Given this list of marker genes RAD51B, TGIF2-RAB5IF, JADE1, CDKN2AIP, IRS1, PRR18, PSME3, HLA-DOB, MYLK, HERPUD2, SUFU, ZNF106, LOXL2, SNCA, ATF7, PLP2, SOX6, DDX31, ZNF609, MMAA, SPTY2D1, FBXL7, KDM3B, RRAS2 (NCBI Gene Id 22800), KLF4, TAB2, PTAR1, CCDC43, COMMD7, DPYSL3, OGT, IPO11, CCDC66, DIRAS1, IGSF9B, SP1, ANKRD36B, FPGT, KLF12, QTRT2, KBTBD2, ZNF275, CALM3, RAF1, FNDC4, HS3ST5, TMED9, SLC5A3 (solute carrier family 5 member 3), RSBN1, MAPKAP1, DCSTAMP, RB1, PRKCB, PCDHB15, ISY1, FHIT, RBFOX1, UGGT1 (UDP-glucose glycoprotein glucosyltransferase 1), GATA5, REG3G, GKAP1, TFF3, SEMA4C, KLHL14, CNPPD1, MTFR1L, RSPRY1, ATP2B2, VPS26A, KIF16B, ZNF395, SLC4A7, HPCAL4, UBXN2B, BLOC1S4, HMG20A, DNAH14, SEPTIN8, PDE4A, IDE, GABRA6, CHD3, ZBTB1, ARL8B, TBC1D12, RAB5IF, MECP2, ZBTB22, PIGH, SHANK1 (SH3 and multiple ankyrin repeat domains 1), WDR47, SOCS2, SQSTM1, XPO7, MFSD14B, SLC25A16, KIF13A, PDK3, ICA1L (NCBI Gene Id 65068), ARID4A, SEPTIN10, GRP, FCHO2, SMARCD1, IDS, STIMATE, PLXNA1, DACH1, NDST3, ARF4, FAM168B, EOLA1 (endothelium and lymphocyte associated ASCH domain 1), RBSN, SRRM3, NR4A3, IRS2, NR2C1, GLI3, CHAMP1, ULK2, RPS6KB1, GFM1, RNF144A, MAFG, NREP, MEGF9, P3R3URF-PIK3R3, ATXN1, UBQLN4, VDAC1, TPGS2, NF2, ARID2, GGA2, PLCB1, SNAP91, RGS7BP, C1orf226, AK3, SH3GLB1, FAM131B, PTK2, BCCIP (NCBI Gene Id 56647), RAB11FIP5, SHOC1, FBXL16, SUSD6, GUCY1A1, DPYSL2, DCK, ZFX, RLIM, NOVA2 (NCBI Gene Id 4859), ZNF805, CGGBP1, IMPG1, TCF12, LRRC59, GRIN2A, ZNF425, CALHM4, ANO3, ACSL4, SHANK2, APOA2, CNNM4, EXOSC2, DAZAP2, NDFIP2, ITGA4, SGIP1, FAM168A, CLASP2, C5orf22, PIK3CD, STX6, IL17RB, ANKRD36C, GAL3ST3, DDIT4, EIF4EBP2, PDE4D, OXR1, PAK2, PFN2, PLEC, TRMT13, TRIM33, LRRC8E, GALNT3, LRRC1, ADGRL2, CTSK, ATG4C, DSEL, CHSY3, ST8SIA5, POLE4, ZNF704, STRN, UBLCP1, CCDC186, BICDL2, CKAP4, ZDHHC9, SLC17A6, EGLN3, CYTH3, TMEM97, DSG1, IGLON5, MIS12, RABEP1, CLEC4M, ZNF549, SATB1, HDLBP, PAN2, ANKFY1, OSBPL11, UBR5 (NCBI Gene Id 51366), B3GLCT, STRN3, GATA6, GJC1, PRDM6, CPTP, RELA, ZC3H4, ABCA13, USF3, SPATA2, CTSB, SLC6A9, ERI2, ADAM11, LEMD3, CACNG7, CA10, WASF3, ADCY9, DOCK5, PIK3R3, DTYMK, ASXL1, HCN1, RHBDD1, CNN3, RNF141, FOXN3, AMOT, VDAC3, NXT2, EPHA3, CCL16, FBXO28, ST6GALNAC5, CYLC1, COLEC12, RYK, SDHC, EGFR, RBMS3, FGD6, PPP4R1, PARP1, LMNB1, CACNB4, CADM3, here is a description of the gene set: species: Homo sapiens from publication Chen Y, Wang X (PMID 31504780) Genes predicted to be targets of miRBase v22 microRNA hsa-miR-7-5p in miRDB v6.0 with MirTarget v4 prediction scores > 80 (high confidence targets). Human Gene Set: MIR7_5P